Given this list of marker genes GNS, here is a description of the gene set: part of: Mucopolysaccharidoses Mucopolysaccharidosis III (Sanfilippo syndrome) was described in 1963 by a pediatrician named Sylvester Sanfilippo (J. Pediat. 63: 837-838, 1963, no reference). Mucopolysaccharidosis type IIID (MPS IIID, Sanfilippo syndrome D, MIM:252940) is an autosomal recessive genetic disorder due to the loss of N-acetyl-D-glucosamine 6-sulfatase (GNS; MIM:607664), that hydrolyses the 6-sulfate groups of the N-acetyl-D-glucosamine 6-sulfate units of the glycosaminoglycans (GAGs) heparan sulfate and keratan sulfate. GNS is localized to chromosome 12q14 and has 14 exons spanning 46 kb. Loss of enzyme activity leads to lysosomal accumulation and urinary excretion of heparan sulfate and N-acetylglucosamine 6-sulfate residues. Keratan sulphate does not accumulate in MPS IIID, as beta-linked N-acetyl-D-glucosamine 6-sulphate can be cleaved by beta-hexosaminidase A. This disorder is characterized by progressive mental deterioration but only moderate physical abnormalities and death duing the second or third decade of life, presenting a phenotype similar to MPSIIIA. species: Homo sapiens Reactome Pathway: MPS IIID - Sanfilippo syndrome D